Given this list of marker genes RAB11FIP4, DYRK1A (dual specificity tyrosine phosphorylation regulated kinase 1A), MBNL2, PTTG1, CBX4, SLC35D3, BTBD1, SERPINE1, WDHD1, UBE2H, TGFBR2, HLA-B (NCBI Gene Id 730410), KLHL24, YPEL2, CSRP2, PPP2CA, CGGBP1, GADD45G, VEGFA, KPNA1, RBM38, CPT1A, GDAP2, CDC42SE2, WDR45B (WD repeat domain 45B), SBSN, MEX3B, ABHD5, HLA-DOB, TRRAP, RASGEF1B, ANKRD50, SIPA1, ZNF212, TSPAN13, RPL26 (NCBI Gene Id 6154), FAM171B, EFNB2, ZBTB34, SGPL1, CKB, CHCHD7, FOXO4, SLC12A4, FAM117A, LMNA, CCNG2, CLK1, E2F1, PHF6, TMEM43, MFSD2A, BAZ2A, CPEB4, ZBTB2, RPS6KA6, ATP1B3, VPS37B, CHCHD10, PCYOX1, NFAT5, SLC16A10, KLHL15, CENPL, OSER1, LCMT1, ACAP3, BAMBI, RASGRP2, BRPF1, HIVEP3, NEU2, RUNX3, GADD45A, TOPORS, DEXI, RYBP, FPGS, MSL1, ARMCX4, MAFF, KIT, USP48, KLHL7, SETD1A, RNF2, FOXO1, WASF2, SAT1, RHOB (ras homolog family member B), SOS1, STMN1, CXCL10, CCPG1, IL4R, AFF4, PARD6A, SLC7A6OS, IRF8, MEX3A, PHETA1, ERF (ETS2 repressor factor), ADH1C, DHX40, GLUL, CENPJ, KLHL11, USP12, ZFTA, RPL4, TP53BP2, ZFP36L1, DOT1L, MKNK2, ETFDH, CPTP, MED13, LFNG, QPRT, MTARC1, DYNC1H1, JUN, TOR2A, SLC2A1, DDX11, ZNF655, FAM83G, KBTBD11, OGFRL1, DUSP2, RRBP1, AFF1, PGRMC1, GGNBP2, BACH1, EXT1, ARID1A, APPL1, LIN54, KLF10, CYTH2, ZCCHC12, H2AX, MTMR14, SLC66A2, FAM53C, WHAMM, TNFRSF12A, RSRC2, IRF5, IKZF5, ZNF326, MYLIP, ZSWIM8, TOB2, PWWP3B, TMEM120B, LAPTM4B (NCBI Gene Id 55353), DEF6, FEM1C, CSRNP2, ARID5A, SFR1, PDCD7, FZD9, ANAPC7, ZNF707, PAPSS1, ATP6V0E1, ARHGAP39, TAGLN, SBK1, BCR, IFFO2, EEIG2, RIPOR2, ATOSA, ELAC2 (elaC ribonuclease Z 2), FBRSL1, CAND1, ICAM1, PALLD, SGSM3, PRDX6, FNIP1, MCMBP, PRPSAP1, MSANTD2, MAPK14, NHERF1, RELL1 (RELT like 1), TEX2, AGO2, TMX4, GLA, TSPAN9, ZYG11B, SUCO, GPANK1, ACSL3, here is a description of the gene set: species: Homo sapiens Genes down-regulated in B lymphocytes: untreated versus anti-IgM for 24h. The activation signaling of transcription factor nuclear factor-kB (NF-kB) plays central role for immune system. One of key kinase mediating this pathway is TAK1 in adaptive and innate immunity. However, role of TAK1 in B cell receptor signaling is still unclear. To know effects of TAK1-deletion on the gene expression induced by anti-IgM, we performed the time course analysis in comparison of wild type with TAK1-deleted splenic B cells. from publication Shinohara H, Behar M, Inoue K, Hiroshima M, Yasuda T, Nagashima T, Kimura S, Sanjo H, Maeda S, Yumoto N, Ki S, Akira S, Sako Y, Hoffmann A, Kurosaki T, Okada-Hatakeyama M (PMID 24833394) Human Gene Set: GSE41176_UNSTIM_VS_ANTI_IGM_STIM_BCELL_24H_DN